Given this list of marker genes Nfkbib, Cd14, Foxo1, Cd44, Thbd, Snx8, Msmp, Siglec1, Cd19, Clic4, Foxn1, Ffar2, F3, Bbs12, Nkg7, Lrrc8e, Adam17, Ifi204, Tradd, Irak2, Npy1r, Ifi35, Mcpt1, Enpp2, Nmi, C3, Lrrc19, Peli1, Gba1, Prkce, Zdhhc1, Mapkapk2, Pilrb1, Sgms1, Rhbdf2, Lep, Arid5a, Plekhf1 (NCBI Gene Id 72287), Tnf, Apba3, Il6ra, Mstn, Parp1, Myd88, Ifngr1, Sra1, Ikbkb, Il22, Mif, Lacc1, Tlr2, Ticam1, Ifit2, Mbl1, Irak4, Hectd3, Irf5, here is a description of the gene set: studied in species Mus musculus Mouse genes annotated to decreased circulating tumor necrosis factor level (MP:0008554) retrieved from the Mouse Genome Informatics database via MouseMine from publication Motenko H, Neuhauser SB, O'Keefe M, Richardson JE (PMID 26092688) Mouse Gene Set: MP_DECREASED_CIRCULATING_TUMOR_NECROSIS_FACTOR_LEVEL